Given this list of marker genes Vcpip1, Ywhaz, Map2k2, Stk25 (serine/threonine kinase 25 (yeast)), Cdk1, Map2k1, Plk3, Vps13b, Stx5a, Gbf1, Golga2, Mapk3, Vrk1, Pdcd10, Mapk1, here is a description of the gene set: studied in species Mus musculus The partitioning of organelles between daughter cells at cell division. Mouse Gene Set: GOBP_ORGANELLE_INHERITANCE